The following is a description of a gene set: A tumor (abnormal growth of tissue) of the uterine cervix. species: Homo sapiens Human Gene Set: HP_CERVICAL_NEOPLASM Cervical neoplasm, and this is the list of marker genes: FGFR3, GATA2, SRY (NCBI Gene Id 6995), STK11, CDKN1B, CXCR4, MAD1L1